Given this list of marker genes SNORD113-5 (NCBI Gene Id 767565), MIR409, MIR377, MIR431, MIR323A, SNORD114-21, MIR433, MIR299 (NCBI Gene Id 407023), MIR337, MIR411, MIR154 (NCBI Gene Id 406946), SNORD113-1, DLK1, MIR544A, MEG3, MIR543, SNORD114-17, MIR376A1, MIR381, MEG8, MIR493, MIR2392, MIR136, MIR323B, SNORD113-2, SNORD114-4, SNORD114-20, MIR541, MIR329-1, SNORD114-15, MEG9, MIR539, MIR495, MIR494, RTL1, SNORD114-18, SNORD114-7, MIR1185-1, MIR487A, SNORD113-7, MIR379, MIR369, MIR134, MIR376C, MIR382, here is a description of the gene set: species: Homo sapiens from publication Carrillo-Reixach J, Torrens L, Simon-Coma M, Royo L, Domingo-Sàbat M, Abril-Fornaguera J, Akers N, Sala M, Ragull S, Arnal M, Villalmanzo N, Cairo S, Villanueva A, Kappler R, Garrido M, Guerra L, Sábado C, Guillén G, Mallo M, Piñeyro D, Vázquez-Vitali M, Kuchuk O, Mateos ME, Ramírez G, Santamaría ML, Mozo Y, Soriano A, Grotzer M, Branchereau S, de Andoin NG, López-Ibor B, López-Almaraz R, Salinas JA, Torres B, Hernández F, Uriz JJ, Fabre M, Blanco J, Paris C, Bajčiová V, Laureys G, Masnou H, Clos A, Belendez C, Guettier C, Sumoy L, Planas R, Jordà M, Nonell L, Czauderna P, Morland B, Sia D, Losic B, Buendia MA, Sarrias MR, Llovet JM, Armengol C (PMID 32240714) Human Gene Set: CARRILLOREIXACH_14Q32OVEREXPRESSION_IN_HEPATOBLASTOMA Genes enriched in locus DLK1-DIO3 at 14q32 in hepatoblastoma (HB) as compared with non-tumor (NT) adjacent tissue assessed by Human Transcriptome Array (HTA). Background & Aims: Hepatoblastoma (HB) is a rare disease. Nevertheless, it is the predominant pediatric liver cancer, with limited therapeutic options for patients with aggressive tumors. Herein, we aimed to uncover the mechanisms of HB pathobiology and to identify new biomarkers and therapeutic targets in a move towards precision medicine for patients with advanced HB.